The following is a description of a gene set: Reactome Pathway: Signaling by EGFR in Cancer The pathway "Signaling by EGFR in Cancer" shows signaling by constitutively active EGFR cancer variants in the context of "Signaling by EGFR", allowing users to compare cancer events with the wild-type EGFR events. Red lines emphasize cancer related events and physical entities, while wild-type entities and events are shaded. Please refer to "Signaling by Ligand-Responsive EGFR Variants in Cancer", "Signaling by EGFRvIII in Cancer" and "Signaling by Overexpressed Wild-Type EGFR in Cancer" for detailed pathway summations. part of: Diseases of signal transduction by growth factor receptors and second messengers species: Homo sapiens, and this is the list of marker genes: CDC37, PLCG1 (NCBI Gene Id 5335), EGF, AREG, BTC, SOS1, UBC, SHC1, KRAS, PIK3R1, UBB, GRB2, HSP90AA1, EREG, HBEGF, UBA52, EPGN, EGFR, HRAS, PIK3CA, CBL, RPS27A, GAB1, TGFA, NRAS